The following is a description of a gene set: This event has been computationally inferred from an event that has been demonstrated in another species.<p>The inference is based on the homology mapping from PANTHER. Briefly, reactions for which all involved PhysicalEntities (in input, output and catalyst) have a mapped orthologue/paralogue (for complexes at least 75% of components must have a mapping) are inferred to the other species. part of: Amine ligand-binding receptors Reactome Pathway: Muscarinic acetylcholine receptors electronically inferred by orthology from the curated human pathway species: Mus musculus, and this is the list of marker genes: Chrm3, Chrm4, Chrm1, Chrm2